The following is a description of a gene set: Human Gene Set: chr3q13 studied in species Homo sapiens, and this is the list of marker genes: GOLGB1, RN7SL815P, OR7E100P, ZBTB20-AS2, HHLA2 (HHLA2 member of B7 family), CCDC191, NECTIN3-AS1, VPS26AP1, SLC9C1, MIR4445, RPL34P9, TMPRSS7, ZBTB20-AS3, MYH15, CCDC80, RN7SL767P, RNU6-1200P (NCBI Gene Id 106481559), RETNLB, BRD7P7, RNU1-43P, RNU6-1127P, CASR, ZBTB20-AS1, NFYBP1, LSAMP, C3orf85, SNORA70, PLA1A, ARHGAP31-AS1, MTND5P16, CCDC54, ZBTB20-AS5, MIR4796, GRAMD1C, NDUFA4P2, NR1I2, MIR4446, TEX55, LINC00635, DPPA2, HNRNPA1P17, LINC00636, LINC02044, ABHD10, RLIG1P2, MTATP6P22, CD80, RPL13P8, MIR567, SIDT1, RPL10P7, DUBR, ENSG00000243276, GCSAM, RNU4-62P, DRD3, TAGLN3, TIGIT, DNAJB1P2 (NCBI Gene Id 127379689), LINC01215, NAA50, STXBP5L, LINC00903, MIR8076, BTLA (NCBI Gene Id 151888), SPICE1-CFAP44, RABL3, SIDT1-AS1 (SIDT1 antisense RNA 1), MIR5682, ATP6V0CP2, ENSG00000239482, MIR548AB, RFKP3, LINC02042, ENSG00000295450, TIMMDC1, MTND4P16, LINC01205 (NCBI Gene Id 401082), MIR198, ENSG00000308491, CFAP44-AS1, SLC15A2, LSAMP-AS1, BOC, CD200R1L, LOLI1, ENSG00000243081, IFT57, PTMAP8, PLCXD2-AS1, BZW1P2, ZNF80, TMEM39A, PPIAP15, MIR4447, ZFAND2AP1, RPL7AP11 (ribosomal protein L7a pseudogene 11), CIP2A, GTPBP8, CD96 (NCBI Gene Id 337949), TBILA, CD86, EIF4E2P2, HCLS1 (hematopoietic cell-specific Lyn substrate 1), TUSC7, POLQ (NCBI Gene Id 29043), MTND3P6, MAT2AP1, PPDPFP1, GAP43, DPPA4, ARHGAP31 (NCBI Gene Id 57514), CSP2, ALCAM, PTPN11P1, ADPRH, IGSF11, RN7SL397P, YBX1P3, RNU6-1308P, SSX2IPP1, RFKP2, POPDC2, PLCXD2, GPR156, FCF1P3, CD47, GUCA1C, CD200R1P1, TUBBP11, GSK3B, MTND6P6 (MT-ND6 pseudogene 6), ENSG00000303327, DZIP3, SPICE1, B4GALT4-AS1, CD200R1, MTND1P16, PTOV1P1, QTRT2, TIMMDC1-DT, ENSG00000221633, CD200, ATP5PBP8, ARGFX, LINC00882, PARLP1, BBX (NCBI Gene Id 56987), LINC00488, MIR568, NECTIN2P1 (NCBI Gene Id 127379749), DBTP1, CTDNEP1P1, RNU6-1236P, ZDHHC23, ATG3, LINC02024, ILDR1, ATOSBP1, LINC00901, CBLB, RN7SL172P, B4GALT4, RAP1BP2, NT5C3AP2, LINC01990, MTCO3P35, SLC35A5, ENSG00000286660, MTCO1P35, EAF2, CFAP44, ZBTB20, RPS10P4, RNU6ATAC15P, BTNL12P (NCBI Gene Id 100130701), ATP6V1A, ZBTB20-AS4, NECTIN3, USF3, H3P12, HGD, CD200LP, LRRC58, DIMT1P1 (NCBI Gene Id 100422385), NEPRO-AS1, CD200R1L-AS1, MTND2P14, CDK2AP1P1, INAVAP1, MORC1, MTCO2P29, ARPC1AP1, PHLDB2, ZBED2, TRAT1 (NCBI Gene Id 51488), DRG1P2, GSK3B-DT, MTCO1P29, RNU5E-8P, POGLUT1, FSTL1 (follistatin like 1), C3orf52, IGSF11-AS1, LINC03051, UPK1B, NDUFB4, EZRP1, CFAP91, CCDC54-AS1, RN7SL762P, RPSAP29, IQCB1, MTND4LP3, NAP1L1P3, MORC1-AS1, H2BP3, GTF2E1, PHB1P8, COX17, RN7SL582P, LINC02049, FBXO40, RABGGTBP1, RPS26P21, NEPRO